Given this list of marker genes STEAP3, FARS2, CP, HBB, SLC11A2, BCS1L, GLRX5, FTH1, BMP6, PIGA, FTL, FOCAD, here is a description of the gene set: Elevated hepatic iron concentration An increased level of iron in liver tissues. Human Gene Set: HP_ELEVATED_HEPATIC_IRON_CONCENTRATION studied in species Homo sapiens